Given this list of marker genes TPRA1, PADI6, PIK3CB, ERCC2, CUL3, NR5A2, TOP1, AATF, TOP2A, here is a description of the gene set: Human Gene Set: GOBP_EMBRYONIC_CLEAVAGE species: Homo sapiens The first few specialized divisions of an activated animal egg.